The following is a description of a gene set: Mouse Gene Set: GOBP_VITAMIN_METABOLIC_PROCESS studied in species Mus musculus The chemical reactions and pathways involving vitamins. Vitamin is a general term for a number of unrelated organic substances that occur in many foods in small amounts and that are necessary in trace amounts for the normal metabolic functioning of the body. Vitamins may be water-soluble or fat-soluble and usually serve as components of coenzyme systems., and this is the list of marker genes: Rdh19, Rdh1, Pm20d2 (NCBI Gene Id 242377), Nnmt, Cyp2r1, Cyp26c1 (NCBI Gene Id 638794), Slc19a3, Strap, Cyp27b1, Mmadhc (methylmalonic aciduria (cobalamin deficiency) cblD type, with homocystinuria), Akr1b1, Rdh16f2, Snai1, Pdzd11, Ubiad1, Cyp27a1 (cytochrome P450, family 27, subfamily a, polypeptide 1), Pdxp, Aldh1l1, Clstn3, Vnn3 (vanin 3), Aldh1l2, Ugt1a6a, Nmnat2, Btd, Atp1a3, Prmt3, Slc52a2, Ifng, Lrat, Nampt, Rgn, Pdxk, Thtpa, Cd320, Mtrr, Clybl, Gclc, Akr1a1, Shmt1, Dhfr, Aifm2, Ero1a, Abcd4, Nmnat3, Mtr, Cyp26a1, Gulo, Rdh10, Mmachc, Fgf23, Isx, Ggcx, Cbr1, Cubn, Cyp4f40, Cyp26b1, Slc5a6, Cbr3, Dgat1, Ttpa, Vkorc1l1, Fgfr1, Acp3, Vkorc1, Akr1c18, Nqo1, Enpp1, Rfk, Vnn1, Mmab, Flad1, Alpl, Lrp2, Rdh9, Mmaa, Gsto1, Selenon, Pltp, Hlcs, Slc23a2, Cbr1b, Gc, Npc1l1, Snai2, Slc25a19, Atp1a2 (ATPase, Na+/K+ transporting, alpha 2 polypeptide), Folr1 (NCBI Gene Id 14275), Rbp1, Cyp24a1, Nfkb1, Tnf, Slc19a2, Nmnat1, Rdh16, Mthfsl, Gfi1, Gsto2, Sp1, Slc52a3, Tpk1, Pnpo, Plpbp, Amn, Lipa, Fgfr4, Klf9, Cyp2w1